Given this list of marker genes PTTG1IP, PLXNC1, HMOX1, NOTCH2, PLAGL1, S100A8, TNFRSF1B, TFE3, CTNNA1, CORO1C, KLF4, TBC1D2, DUSP6, CD33, ATG7, PTPRE, GLUL, SEMA4A, QPCT, ABHD5, FCER1G, RIN2, SERPINA1, RAB31, LILRB3 (leukocyte immunoglobulin like receptor B3), PILRA, FGR, LILRB2, DHRS7B, PTGS1, PRKCD, SYK, VAMP3, PLBD1, TBC1D12, MNDA, PLXNB2, STX12, SLC7A7, COQ2, SNX11, ARID3A, GCA, CLCN6 (chloride voltage-gated channel 6), ANXA2, SLC15A3, TNFSF13, IGSF6, MARCKS, CTSH, BACH1, SLC16A6, TNFRSF10B (NCBI Gene Id 8795), KCNMB1, SMCO4, FTL, ASAH1, KCTD12, RAB32, CKAP4, CSF2RB, SLC1A5 (solute carrier family 1 member 5), NCOA4, SIGLEC9, HS1BP3, NADK, TOR4A, MAFB, ACOT9, PLCG2, LAPTM5 (NCBI Gene Id 7805), LILRB1, CYBB, TMEM127, RXRA, TYROBP, LILRA2, HEXB, MCTP1 (NCBI Gene Id 79772), CSF3R, LY96, CTBP2, DPYD, NPL, CAPG, TET3, CSF1R, TLR2, EXOC1 (exocyst complex component 1), FCGR2A, MTMR11, ADPGK, SH3TC1, FPR1, SDCBP, WASHC4, APOBEC3A, PSAP, CTSS (NCBI Gene Id 50653), SNCA, DMXL2, PTAFR, FTH1P5, NPC2, NCF2, CHST15, CREG1, SUOX, MBOAT7, LGALS3, USP15, MTMR14, CERT1, BCL3, ATP6V1A, SIRPA, LEPROT, SLC11A1, MFSD1, EXT1, CYRIA, ACSL1, CD93, OAZ1, IFNGR2, ARHGAP26, GNS, S100A9, CLEC4A, FBP1, CTSB, GAB2, LTBR, METTL9, BCL6, TNS3, QSOX1, DUSP3 (NCBI Gene Id 284066), FGL2, LAT2, FEZ2 (NCBI Gene Id 9637), RTN1, USP3, DAPK1, AP1S2, CSTA, IRAK3, SLC16A3, TNFAIP2, CPVL, FLVCR2, MANBA, PPFIA1, C5AR1, CDC42EP3, FCN1, NAGK, SAT1, VCAN, MGAT1, CEBPD, ARAP1, CFP, ZMIZ1, CD36, TIMP2, ALOX5, CAPZA1, IFNGR1, PGD, WARS1, AKR1A1, NOD2, APP (NCBI Gene Id 351), ETV6, PPM1H, ADAP2, GPX1, HSPA1A, SLC27A3 (NCBI Gene Id 79181), SLC31A2, IRF8, BID, PISD, ANXA2P2, HCK, CST3, S100A11, S100A12, CCR1, LYN, LYZ, MS4A6A, APLP2, RNF130, IFI30, CD14, CLEC7A, TGFBI, GRN (granulin precursor), here is a description of the gene set: Genes down-regulated in comparison of naive CD8 T cells versus day 0 monocytes. studied in species Homo sapiens Immune cell-specific expression is one indication of the importance of a gene's role in the immune response. In order to identify such patterns, we set out to broadly profile gene expression in a variety of immune cells. from publication Abbas AR, Baldwin D, Ma Y, Ouyang W, Gurney A, Martin F, Fong S, van Lookeren Campagne M, Godowski P, Williams PM, Chan AC, Clark HF (PMID 15789058) Human Gene Set: GSE22886_NAIVE_CD8_TCELL_VS_MONOCYTE_DN